The following is a description of a gene set: studied in species Homo sapiens Interhemispheric cyst Cystic collection (sac-like, fluid containing pocket of membranous tissue) located in the interhemispheric fissure, with or without communication with the ventricular system. Human Gene Set: HP_INTERHEMISPHERIC_CYST, and this is the list of marker genes: DCC, LMNB2 (NCBI Gene Id 84823), MAN2C1, PLCH1, RNU4ATAC, L1CAM, CDH2